The following is a description of a gene set: species: Mus musculus Mouse Gene Set: HU_GENOTOXIN_ACTION_DIRECT_VS_INDIRECT_24HR During the safety evaluation process of new drugs and chemicals, a battery of genotoxicity tests is conducted starting with in vitro genotoxicity assays. Obtaining positive results in in vitro genotoxicity tests is not uncommon. Follow-up studies to determine the biological relevance of positive genotoxicity results are costly, time consuming, and utilize animals. More efficient methods, especially for identifying a putative mode of action like an indirect mechanism of genotoxicity (where DNA molecules are not the initial primary targets), would greatly improve the risk assessment for genotoxins. To this end, we are participating in an International Life Sciences Institute (ILSI) project involving studies of gene expression changes caused by model genotoxins. The purpose of the work is to evaluate gene expression tools in general, and specifically for discriminating genotoxins that are direct-acting from indirect-acting. Our lab has evaluated gene expression changes as well as micronuclei (MN) in L5178Y TK(+/-) mouse lymphoma cells treated with six compounds. Direct-acting genotoxins (where DNA is the initial primary target) that were evaluated included the DNA crosslinking agents, mitomycin C (MMC) and cisplatin (CIS), and an alkylating agent, methyl methanesulfonate (MMS). Indirect-acting genotoxins included hydroxyurea (HU), a ribonucleotide reductase inhibitor, taxol (TXL), a microtubule inhibitor, and etoposide (ETOP), a DNA topoisomerase II inhibitor. Microarray gene expression analysis was conducted using Affymetrix mouse oligonucleotide arrays on RNA samples derived from cells which were harvested immediately after the 4 h chemical treatment, and 20 h after the 4 h chemical treatment. The evaluation of these experimental results yields evidence of differentially regulated genes at both 4 and 24 h time points that appear to have discriminating power for direct versus indirect genotoxins, and therefore may serve as a fingerprint for classifying chemicals when their mechanism of action is unknown. from publication Hu T, Gibson DP, Carr GJ, Torontali SM, Tiesman JP, Chaney JG, Aardema MJ (PMID 15120960) Genes discriminating between direct (cisplatin, MMS, mitomycin C) and indirect (paclitaxel, hydroxyurea, etoposide) acting genotoxins at 24 h time point., and this is the list of marker genes: Psma2 (NCBI Gene Id 19166), Hs1bp3, Sowahc, Tinf2, Ric8a, H2-Q2, Ift25, Ptp4a1, Incenp, Apex1, Ypel3, Hnrnpul2, Cct3, Lypla2, Mif4gd, Glrx3, Pag1, Gstm6, Nelfe, Rtcb, Tnfrsf18, Mst1, Hdac6, Krt4, Fcho1, H2bc13 (H2B clustered histone 13), C4a, Fastk, Ipp, Mtdh, Npm1, Atp5f1c, Emp3, Ube2e1, Ptma, Ncl, Api5, Nus1, Tomm34, Nubp1, Ubxn11, Dnajb6, Syncrip, Top2a, Junb, Strn, Slc50a1, Rbbp7, Rb1, Hsd3b4 (NCBI Gene Id 15495), G3bp2, Creb3l1